The following is a description of a gene set: Reactome Pathway: p53-Dependent G1/S DNA damage checkpoint The arrest at G1/S checkpoint is mediated by the action of a widely known tumor suppressor protein, p53. Loss of p53 functions, as a result of mutations in cancer prevent the G1/S checkpoint. P53 is rapidly induced in response to damaged DNA. A number of kinases, phosphatases, histone acetylases and ubiquitin-conjugating enzymes regulate the stability as well as transcriptional activity of p53 after DNA damage. species: Homo sapiens part of: G1/S DNA Damage Checkpoints, and this is the list of marker genes: PSMC6, CDKN2A, PSMA7, PSMA6, PSMB6, PSMD8, PCBP4, ATM (ATM serine/threonine kinase), PSMD14, PSMD1, PSMB3, CCNA2, MDM4, CCNE2 (NCBI Gene Id 9134), UBA52, COP1, CDKN1B, CDKN1A, PSMC3, CDK2, RPS27A, CHEK2, PSMC5, PSMC4, TP53, PSMD3, PSMD12, PHF20, PSMC1, PSMB5, PSMA1, PSMD7, UBC, SEM1, PSMB1, PSMD2, CCNE1, MDM2, PSMA3, UBB, ZNF385A, PSMB7 (NCBI Gene Id 5695), PSMB2, PSMA2, PSMC2, CCNA1, PSMB4, PSMD11, PSMA5, PSMD6, PSMA4, PSMD13, ADRM1